The following is a description of a gene set: studied in species Homo sapiens Human Gene Set: GOBP_NEGATIVE_REGULATION_OF_ENDOTHELIAL_CELL_DIFFERENTIATION Any process that stops, prevents, or reduces the frequency, rate or extent of endothelial cell differentiation., and this is the list of marker genes: JAG1, ACVRL1, ZEB1, MIR10A, FOXJ2, MIR495, VEGFA, MIR1-1, S1PR3, DSG2, NOTCH4